The following is a description of a gene set: Cytokines mediate cell-cell communication in the immune system and represent important therapeutic targets. A myriad of studies have highlighted their central role in immune function, yet we lack a global view of the cellular responses of each immune cell type to each cytokine. To address this gap, the authors created the Immune Dictionary, a compendium of single-cell transcriptomic profiles of more than 17 immune cell types in response to each of 86 cytokines (>1,400 cytokine-cell type combinations) in mouse lymph nodes in vivo. A cytokine-centric view of the dictionary revealed that most cytokines induce highly cell-type-specific responses. For example, the inflammatory cytokine interleukin-1β induces distinct gene programmes in almost every cell type. A cell-type-centric view of the dictionary identified more than 66 cytokine-driven cellular polarization states across immune cell types, including previously uncharacterized states such as an interleukin-18-induced polyfunctional natural killer cell state. from publication Cui A, Huang T, Li S, Ma A, Pérez JL, Sander C, Keskin DB, Wu CJ, Fraenkel E, Hacohen N (PMID 38057668) Genes positively differentially expressed in cell type: Treg upon treatment with cytokine: IL-12 in mouse lymph nodes in vivo. Mouse Gene Set: CUI_TREG_IL12_RESPONSE_UP studied in species Mus musculus, and this is the list of marker genes: Parp14, Psmb9, Xaf1, Zbp1, Tap2, Dtx3l, Irf8, Psmb8, Arhgef1, Irf1, Stat1, Psmb10, Tap1 (transporter 1, ATP-binding cassette, sub-family B (MDR/TAP)), Gbp2, Ifi47, Rtp4, Samhd1, Gbp4, Iigp1, Igtp, Tcstv4, 9930111J21Rik2, Irf9, Irgm1, Socs1, Gbp7, Trim21, Tcof1, H2-T23, Trim34a, Mitd1